The following is a description of a gene set: Any process that modulates the frequency, rate or extent of the controlled release of a substance from a cell or a tissue. Mouse Gene Set: GOBP_REGULATION_OF_SECRETION studied in species Mus musculus, and this is the list of marker genes: Cyp19a1, Rfx3, Vps35, Drd3, Ric1, Rab37, Fgb, Hrh3, Nadk, Aacs, Chrna4, Ildr1, Clock, Mapk9, Rab21, Foxl2, Zp3, Il6, Capn10, Cldn2, Mmp13, Adcy5, Myo18a, Ces1e, Stxbp1, P2rx2 (NCBI Gene Id 231602), Rph3al, Corin, Prl8a8, Ano1, Mtnr1b, Trh, Itgb2, Cd200, Avp, Gip, P2ry4, Tlr2, Slc6a1, Tm7sf3, Myrip, Ecrg4, Prl2b1, Braf, Ppp3ca, Trem2, Rhbdf2 (NCBI Gene Id 22254), Psmd9, Crhr2, Pard6a, Mctp1, Kdm5b, Cd2ap, Rest, Sdhd, Hcar2, Syt9, Pram1, Atg7, Ntrk2, Hgs, Gata1, Bcl2l1 (NCBI Gene Id 12048), Cd74, Grik1, Cacna1c, Sergef, Fcer1g, Chmp2a, Cyp4a10, Tfr2 (NCBI Gene Id 50765), Ppia, P2ry12, Sct, Sphk2, Sytl2, Itgb2l, Cplx4, Map2k6, Jagn1, Pld2, Alox5, Prl8a6, Gnai2, Ces1f, Ggcx, C1qtnf3, Rab3gap1 (RAB3 GTPase activating protein subunit 1), Slc16a1, Cacna1g, Oas2, Nckap1l, Adora1, Rab27b, Egf, Gpld1 (glycosylphosphatidylinositol specific phospholipase D1), Htr2a, Tprg1l, Pla2g10, Cplx3, Bsg, Git1, Cd177, Mup3, Cplane2, Rab3a, Ucn, Rab26, Clcf1, Gnai1, Chrna3, Apbb3, Atp9a, Unc13a, Pcp4, Abr, Hip1r, Mir200a, Cyp4a32, Xbp1, Cacna1h, Uqcc2, Ucp2, S100a9, Srcin1, Notch1, Kcnj6, Prl8a1, Grp, Cd38, Fbn1, Fgr, Agt, Blk, Hyal3, Prl7d1, Igf1 (insulin-like growth factor 1), Stx1a, Lep, Map4k4, Vamp8, Rhbdd1, Ins2, Lrrk2, Bmal1, Mup11, Tmf1, Sytl4, Srebf1, Dpysl2, Slc2a2, Exph5, Sv2b, Lepr, Birc5, Tac1, Git2, D6Wsu163e, Edn3, Sstr5, Spx, Arhgef7, Gpr151, Prl2a1, Nr3c1, Ang2, Apoe, Sdc1, Htr1b, Prl2c3, Igfbp3, Lrp5, Krt20, Sec24a, Hnf4a, Ces1c, Cnr1, Cckar, Adtrp, Rac1, Syt15, Exoc2, Prepl, Epb41l1, Nmu, Tnfsf11, Pck2, Abcg1, Sfrp1, Chrm3, Gipr, Sybu, Oxt, Ghsr, Mup2, Rab11fip1, Ptbp1, Dvl1 (NCBI Gene Id 13542), Hnf1a, Ptpn11, Prl7b1, Spi1, Il1a, Prkcq, Neo1, Agtr2, Slc18a1, Septin5, Neurog1, Ces1d, Inhbb, Rfx6, Vdr, Cplx1, Osm, Abat, Ifnb1, Negr1, Stk39, Hcfc1, Rims1, Cckbr, Pclo, Orai1, Trpm5, Avpr1a, Cyp51, Ptger3, Glp1r, Il1rapl1, Glul, Slc8b1, Myo5a, Prl3b1, Kcnk9, Rab2b, Tnfrsf1a, Rab33b, Clasp1, Htr1a, Rab3b, Kiss1r, Syt11 (NCBI Gene Id 99745), Atp13a2, Il12a, Atp5pf, Sdc4, Itgam, Clasp2, Prl3c1, Vps4b, Hmgcr, Ep300, Fgf10, Mir130a, Kcna2, Fgfr4, Wnt7a, Bglap, Ccl5, Foxf1, A1cf, Htr7, Map1lc3b, Pdcd6ip, Tgfb1, Eny2, Stxbp4, Pim3, Scg5, Ucn2, Il13, Rab11fip5, Mif, C2cd2l, Rab5a, Ccn3, Ier3ip1, Ap1g1, Atg5, Anxa1, Rab15, Gnaz, Apln (NCBI Gene Id 77874), Drd4, Arf6 (NCBI Gene Id 11845), Lrrc8a, Sirt6, Nkx6-1, Alox12b, Oxtr, Tacr1, Ntsr1, Kcnj11, Klf7, Lypd11, Cyba, Cry1, Prkaca, Glud1, Nf1, Tlr4, Nlrp6, Atp2a2 (NCBI Gene Id 319250), Slc6a4, Ppp3cb, Rap1a, Grm7, Rtn4, Gal (galanin and GMAP prepropeptide), Fam3d, Aimp1, Npsr1, Bad, Grm2, Kcnq1, Rab7, Idua, Sv2c, Jak2, Sphk1, Sirt3, Prl3d3, Stam, Fmr1, P3h1, Syt5, Rhbdd3, Pdpk1, Trpm2, Rasl10b, Cbarp, Prl2c1, Rab9, Pnkd, Prl3d2, Rab27a, Cspg5, P2ry1, Prkar1a, Kcnb1, Adora2b, Abcc8, Prkcb, Pax8, Bmp2, Cd300a, Dab2, Grm8, Cyp4a31 (NCBI Gene Id 666168), Anxa7, Ms4a2, Nr1h4, Lgals9, Tardbp, Pofut2, Midn, Prkn, F2rl1, Gab2, Dynll1, Tmed10 (transmembrane p24 trafficking protein 10), Nnat, Ankrd1, Abca12 (ATP-binding cassette, sub-family A member 12), Plcb1, Gpr158, Myo6, Ces1a, Ahi1, Grk2, Trpm4, Snf8, Tspoap1, Kiss1, Chrna7, Ang4 (NCBI Gene Id 328486), Tff2, Cacna1d (calcium channel, voltage-dependent, L type, alpha 1D subunit), Stxbp3, Gdf9, Mlxipl, Brsk2, Vamp3, Ndufaf2, Rab34, Nkx3-1, Smcr8, Zbed6, Tmed10-ps, P2rx7, Rap1gds1, Ghrhr, Selenot, Dnm1l, Mctp2, Rhot1, Myh9, Npr3, Ucn3, Syt13, Cyp27b1, Syt3, Frmd4a, Retn, Gprc6a, Chrnb2, Rbp4, Pfkm, Septin4, Stc1, Smpd3, Npy, Rph3a, Ptgs1, Cd84, Idh2, Nell2, Cxcl12, Fto, Sri, Hrh2, Oga (NCBI Gene Id 76055), Kcnc3, Myb, Tunar, Ncs1, Ppid, Vegfc, Il1b, Lyn, Cadps2, Septin1, Plcd1, Nr1d1, Asic1, Wnk4, Prl3a1, Gnao1, Syt10, Gck, Tac4, P2ry2, Rab8b, Cask, Inhba, Gnaq, Snap23, Htr6, Snapin, Ppard, Foxo1, Prkg1, Slc18a3, Hif1a, Npy2r, Adora2a, Egfr, Sirt4, Mtnr1a, F2r, Crhbp, Adcy8, Mef2c, Stxbp2, Irs2, Ang, Galr1, C9orf72, Ces1g, Rab3c, Tnf, Dtnbp1, Ptafr, Stxbp5l, Bmp6, Fgf23, Tfap2b, Cacna1b, Pla2g4a, Lgals3, Myt1, Hap1, Syt1, Wls, Sidt2, Slc9b2, Syt2, Pou5f1, Vps18, Tcp11, Tcf7l2, Wdr41, Rptor, Zfp384, Cd160, Anxa2, Ptger4, Pde1c, Or51e2, Prkce, Prl3d1, Ptpmt1, Kcnc4, Lif, Kcnn4, Unc13b, Bcr, Chrna6, Tgfb2, Ghrh (NCBI Gene Id 14601), Lrp1, Cela2a, Rabgef1, Ffar3, Wnk1, Pask, Gja1, Lgi3, Ncoa6, Cacna1a, Fgg, Cntf, Kmo, Rac2, Syk, Abcb11, Tacr2, Micu3, Kalrn, Doc2a, Pfkfb2, Hcrt, Pomc, P2rx1, Rims3, Pfkl, Syt17, Ceacam1, Trpa1, Smad4, Mup5, Osbp, Nos2, Fcer1a, Serp1, Oxct1, Lamp1, Adora3, Tpcn2, Syt7, Ptges, Ang5, Rims4, Il4, Ngf, Myo5b, Cpt1a, Tmem132a, Baiap3, Grin2b, Mup4, Tiam1, Prkcg, Drd2, Slc25a22, Madd, F2rl2, Prl, Cacna1i, Gpr27, Hmga2, Prl8a2, Ces1b, Dph3, Sdcbp, Ica1 (islet cell autoantigen 1), Itsn1, Nherf1, Lypd10 (Ly6/PLAUR domain containing 10), Pde4c, Tifab, Ces1h (carboxylesterase 1H), Erbb3, Cdk16, Efna5, Cftr, Nr1h3, Il1rn, Dnajc1, Uts2, Edn1, Scamp5, Ptpn23, Irs1, Prl4a1, Crh, Vsnl1, Fes, Sox4, Sstr4, Pick1, Slc30a8, Trpc1, Cpb2, Maob (monoamine oxidase B), Ifng, Edn2, Trim9, Prkca, Pfn2, C1qtnf1, Nlgn1, Gna11, Prl5a1, Ffar1, Fbxl20, Anxa5 (NCBI Gene Id 97115), Fbxo45, Gpr68, Nmb, Ptprv, Mup1, Gata2, Ptprn, Cdk5, Arrb1, Adra2a, Cacnb4, G6pc2, Acsl4, Cacna1e, Malrd1, Pink1, Sv2a, Stx1b, Runx1, Camk2a, Gabbr1, Pde8b, Il4ra, Kif5b, Ffar4, Avpr1b, Adam9, Cyp2j5, Snap25, Oprm1, Ins1, Prl2c5, Tspo, S100a8, Htr2c, Hmox1, Wnk3, C1qtnf12, Isl1, Ada (NCBI Gene Id 11486), Nppa, Pdx1, Rala, Npy1r, Inha, Il13ra2, Ang6, Nlgn2, Cadps (Ca2+-dependent secretion activator), Prl7a1, Nsf, Rims2, Casr, Syt6 (synaptotagmin VI), Agtr1a, Myh10, Snca, Mfn2, Sirt1, Gper1, Apbb1 (NCBI Gene Id 11785), Tbc1d1, Oprk1, Adcyap1, Gpr39, Cck, Ptprn2, Piwil4, Stx4a, Itpr1, Il11 (interleukin 11), Adipoq, Il12b, Rap1b, Tcirg1, Nrg1, Rgcc, Slc30a1, Nucb2, Prl6a1, Golph3l, Syt12, Pcsk1, Acvr2a, Crhr1, Aqp1 (NCBI Gene Id 11826), Per2, F2, Prl7a2, Acvr1c, Stxbp5, Sox11, Snx4, Pde3b, Rab11fip3, Rufy4, Nr1h2, Mcu, Fkbp1b, Arf1, Entpd1, Npff, Slc12a2, Gnas, Rsad2, Erp29, Foxa2, Epha5, Prkd1 (protein kinase D1), Cry2, Syt8, Hfe (NCBI Gene Id 15216), Tsg101, Eipr1, Mical1, Kcnh1, Hadh, Syn1, Fgfr1, Rhbdf1, Sncaip, Tmem184a, Creb1, Slc38a2, Tnfrsf11a, Doc2b, Bglap2, Vps4a, Ttn, Ensa, Doc2g, Mir410, Golph3, Npvf, Prl7c1, Syt4, Spp1, Nppc, S100a10, Unc13d, Nr0b2, Cartpt, Ppfia2, Htr1d, Nos1, Arfip1, Rab3d, Gja5, Acsl3, Pparg, Pex5l, Gcg, Snap29, Sncg, Tgfb3, Pla2g6, Tnfrsf1b, Ren1, Rapgef4, Ffar2, Ppp1r9a, Mpc2, Cdk5r2, Vamp2, Npy5r, Hmgn3, Pla2r1, Ccr2, Pla2g3, Prl2c2, Fga, Chd7, Myom1, Slc4a8, Ghrl, Stim1, Prl8a9, Chga, Camk2n1